Given this list of marker genes SNTB2, ADSL, DAD1, CDKN2B, SMARCA4, ADAM9, MKLN1, TUSC2, IRF8, LIPE (lipase E, hormone sensitive type), THAP7, SART3, EDIL3, OSMR, FABP5, PLPBP, HIF1A, EBNA1BP2, B4GALT3, PLG, MCL1 (MCL1 apoptosis regulator, BCL2 family member), SATB1, XPOT, CRISP3, FYN, ITM2C, SSR3, CTRB2, KLHDC2, JUNB, LAG3, CCDC47, APP, KAT2B, ZFP36, FGA, FOS, PKM, EMP1, PIK3CD, AKIRIN1 (NCBI Gene Id 79647), ALDOAP2, CD86, CIAO2A, IER3, RERE, CNDP2, NPNT, IL17RA, OXCT1, PDGFA, STX7, NAB2, TRPC5, IPO4, ROS1, ST3GAL4, ARIH2, ELP3, GALE (NCBI Gene Id 2582), RBM15, SPRED2, COMMD4, FPR2, H2BC18, FBXL5, NCK1, FABP7, RAP1A, HSD3B7, KDELR1, PTN, MAN1A1, PHLDA1, OLFM1, IL6ST, HIPK3, LGALS1, TMEM115, FBXO6, DALRD3, SRP9, RYK, RAP1GDS1, PRRG2, CLN8, CYTH3, CHMP4B, IFITM3, NSMCE1, MARCKS, DGAT1, RPS16, BATF, RPP25L, SRRT, NID2, CD164, ACYP1, CHI3L1, TMCO1, RASGRP1, CDKN1C (NCBI Gene Id 702), GFI1B, BSN, SMAD1, CASP7, MAP2K4, F12, SLC12A3, RAC2, MME, DAB2, FLVCR2, KLHL24, PNPO, CCN2, PHF13, DR1, EZR, RAC1, HFE, RHOU, ADAM11 (ADAM metallopeptidase domain 11), CCNT1, TAC3, THAP12, SERPINE1 (serpin family E member 1), GHRL, IST1, CASP4, SNX1, GSN, GFPT2, BTG3, DUSP16, GADD45A, KIAA2013, FCGR1A, NCAM2, SLC44A2, MAP6, SOWAHC, CRIPT, NKAIN1, PUM2, CDK16, OSER1, CD53, NAV1, LEMD2, EMB, CEBPD, HMBOX1, TAX1BP1, PFKFB3 (NCBI Gene Id 5209), PDRG1, RAB31, PTPN18, RNFT1, TLE3, DUSP2, UGCG, SSBP4, VAV1, LANCL1, HOXD10, RASA1, RELB, CDK5, TBC1D14, GLIPR2, RSRP1, TIAM1, CLIC4, ADD1, EPHA2, PLXNB2, BBS9, TRPC6, HSD17B10, XDH, XBP1, NDUFB11, COX7A2L, MYC, PISD, AKT2, GRHPR, CEL, TRIM46, RNF2, PHF23, TNFRSF1A, NUPR1 (NCBI Gene Id 26471), PLA2G4A, RAB11FIP5, S100A13, PDPN, NHERF1, here is a description of the gene set: studied in species Homo sapiens from publication Yosef N, Shalek AK, Gaublomme JT, Jin H, Lee Y, Awasthi A, Wu C, Karwacz K, Xiao S, Jorgolli M, Gennert D, Satija R, Shakya A, Lu DY, Trombetta JJ, Pillai MR, Ratcliffe PJ, Coleman ML, Bix M, Tantin D, Park H, Kuchroo VK, Regev A (PMID 23467089) Despite their enormous importance, the molecular circuits that control the differentiation of Th17 cells remain largely unknown. Recent studies have reconstructed regulatory networks in mammalian cells, but have focused on short-term responses and relied on perturbation approaches that cannot be applied to primary T cells. Here, we develop a systematic strategy – combining transcriptional profiling at high temporal resolution, novel computational algorithms, and innovative nanowire-based tools for performing gene perturbations in primary T cells – to derive and experimentally validate a temporal model of the dynamic regulatory network that controls Th17 differentiation. The network is arranged into two self-reinforcing and mutually antagonistic modules that either suppress or promote Th17 differentiation. The two modules contain 12 novel regulators with no previous implication in Th17 differentiation, which may be essential to maintain the appropriate balance of Th17 and other CD4+ T cell subsets. Overall, our study identifies and validates 39 regulatory factors that are embedded within a comprehensive temporal network and identifies novel drug targets and organizational principles for the differentiation of Th17 cells. Human Gene Set: GSE43955_TH0_VS_TGFB_IL6_IL23_TH17_ACT_CD4_TCELL_52H_DN Genes down-regulated in CD4 T helper cells (52h): Th0 versus Th17 treated with TGFB1, IL6 and IL-23.